Given this list of marker genes Cdc7, Ino80, Nuggc, Fgfr1 (NCBI Gene Id 14182), Zmpste24, Dbf4, Dach1, Aicda, Wiz, Atrx, Ilkap, Cdt1, here is a description of the gene set: species: Mus musculus Any process that modulates the frequency, rate or extent of The DNA-dependent DNA replication that occurs in the nucleus of eukaryotic organisms as part of the cell cycle. Mouse Gene Set: GOBP_REGULATION_OF_NUCLEAR_CELL_CYCLE_DNA_REPLICATION